Given this list of marker genes ACO1, UBE2L6, LINC01220, TMEM200C, LSM11 (NCBI Gene Id 134353), H4C13, IL2RA, SNX18, NT5DC1, BLID, SH2D2A, DRAM2, KIAA1549 (NCBI Gene Id 57670), HOXA1, HHLA2, HMGA1, B3GNT8, TST, CIMAP1D, SPAG4, SLC12A4, RXFP1, UBAC2-AS1 (UBAC2 antisense RNA 1), FAM20B, IRGC, HBEGF, CAB39L, MELTF, KLHL30-AS1, REXO2, CD79A (CD79a molecule), OR2C3, SIT1, FTCDNL1, TCEA2, GSTA4, MPP1, LINC01561, LINC00837 (NCBI Gene Id 283079), G0S2, FZD1, ZCWPW2, PYGO2 (NCBI Gene Id 90780), SRRM5, SLC12A6, VPREB3, CAST, C3orf36, SLC38A11, ATP1B1, MAPK15, WDR54, ISG15, HSD3B2, AFAP1L2, ZNF277, FOXR2, CXCL13 (NCBI Gene Id 115545), PRIMA1 (proline rich membrane anchor 1), ITGA4, DUSP10, SCN1B, IL5, JPH3, DSC2, ENSG00000291006, SLAMF1, CAV1, BAZ1A, UTS2B, APOBEC3B, CCRL2, PLEKHN1, CBR1, APCDD1, SSBP3 (NCBI Gene Id 55126), PGAP2, SIRPG, FRK, PGK1, ANKRD42, MIIP, GINM1, SPAG8, ZFP42, RNF125 (ring finger protein 125), NT5DC4, LINC00856, ENSG00000258422 (novel transcript, antisense to SLC8A3), GPNMB, LPAL2, BDH1, TXNRD3, GAB2, TWIST2, DPP10, ACTRT3, SLC26A4, CFD, MIR205HG, SYCE1L, RNF39, LZTFL1, DDIT4, GAS8-AS1, MCAM, TMPRSS3, CCDC57, UGT2B4, BEX3, TRAC, DTHD1, GLIS2, SV2A, SCN5A, ZSWIM1, TAB1, LAIR1, F2RL2, SERTAD3, TPBG, C22orf23, PPM1K, CCDC168, ZNF362, TMEM147, HOXA13, SPINT2, CCR4, EML1, RAD51AP1, RNF157-AS1 (RNF157 antisense RNA 1), CACNA1H, BNIP3L, TPCN2 (NCBI Gene Id 219931), ABHD17B, ABCA9 (NCBI Gene Id 10350), DNASE2, DUSP16, KLF8, GZMB, OTUD5, ADGRL4, TRBC1, NKD2, H4C9, NTN1, LINC01097, MGC16275, VDR, EMSY, ZBTB44-DT, MYO15B, MIR622, TRPT1, CYP46A1, ENSG00000254531, RTN2, HAO1, SHISAL2A, CEACAM21, PRRT1, ITM2A, APLP2, EIF3H, NT5C3B, ALDOC, AMPH, NME5, MST1, IGHM, NES, PROSER2-AS1, PTDSS2, LARP1B, CD53, SMYD3, SIX2, CCDC30, PLAUR, TRIM6, DHRS3, P4HA2 (NCBI Gene Id 8974), CRB1, MROCKI, EVI2B, TMIGD2 (transmembrane and immunoglobulin domain containing 2), here is a description of the gene set: studied in species Homo sapiens Conditional macrophage-specific PPARg knockout mice were generated on C57Bl/6 background by breeding PPARg fl/- (one allele is floxed, the other is null) and lysozyme Cre transgenic mice. PPARg and IL-4 signaling was analyzed on bone marrow-derived macrophages. Bone marrow of 3 mice per group was isolated and differentiated to macrophages with M-CSF (20 ng/ml). 20 ng/ml IL-4 was used to induce alternative macrophage activation and 1 uM Rosiglitazone (RSG) was used to activate PPARg. From each mouse 4 samples were generated: 1. M-CSF, 2. M-CSF+RSG, 3. IL-4 and 4. IL-4+RSG. All compounds were added throughout the whole differentiation process, and fresh media was added every other day. Control cells were treated with vehicle (DMSO:ethanol). After 10 days, RNA was isolated and gene expression profiles were analyzed using Mouse Genome 430 2.0 microarrays from Affymetrix. Genes down-regulated in bone marrow-derived macrophages treated with rosiglitazone: wildtype versus PPARG. Human Gene Set: GSE25123_WT_VS_PPARG_KO_MACROPHAGE_ROSIGLITAZONE_STIM_DN from publication Szanto A, Balint BL, Nagy ZS, Barta E, Dezso B, Pap A, Szeles L, Poliska S, Oros M, Evans RM, Barak Y, Schwabe J, Nagy L (PMID 21093321)